Given this list of marker genes Xk (X-linked Kx blood group), Cdhr5, Gla, Nefl, Pls1 (plastin 1 (I-isoform)), Ezr, Ush1c, Nefm, Wnt7b (NCBI Gene Id 22422), Vil1, Cdhr2, Wnt7a, Twf2, Kel (Kell blood group), Cntn2, here is a description of the gene set: A process that modulates the size of a cell projection. Mouse Gene Set: GOBP_REGULATION_OF_CELL_PROJECTION_SIZE species: Mus musculus